The following is a description of a gene set: Cytochrome c-mediated apoptotic response species: Mus musculus Mouse Gene Set: REACTOME_CYTOCHROME_C_MEDIATED_APOPTOTIC_RESPONSE, and this is the list of marker genes: Diablo, Gm10053, Xiap, Casp3, Mapk3, Apip, Aven, Casp9, Mapk1, Apaf1, Casp7, Cycs